The following is a description of a gene set: studied in species Homo sapiens Human Gene Set: REACTOME_GLI_PROTEINS_BIND_PROMOTERS_OF_HH_RESPONSIVE_GENES_TO_PROMOTE_TRANSCRIPTION GLI proteins bind promoters of Hh responsive genes to promote transcription, and this is the list of marker genes: PTCH1, GLI2, GLI1, GLI3, BOC, HHIP, PTCH2